Given this list of marker genes EGFR, ROCK1, GRB10, BRCA2, MAPK6, PTK2, ITGAV, ITGA1, CXCL8, CEACAM1, TPR, LIG3, ADAM9, DSP, MDM2, BIRC3, TGFB2, LAMB1, HNRNPH1, TP53BP2, DMD, here is a description of the gene set: studied in species Homo sapiens Cancer related genes down-regulated in any of four hepatoma cell lines following 24 h treatment with TSA. Human Gene Set: CHIBA_RESPONSE_TO_TSA_DN OBJECTIVE: Histone deacetylase (HDAC) inhibitors have been reported to induce cell growth arrest, apoptosis and differentiation in tumor cells. The effect of the HDAC inhibitor, trichostatin A (TSA), on hepatoma cells, however, has not been well studied. In this study, we examined cell viability and gene expression profile in hepatoma cell lines treated with TSA. METHODS: To study cell growth inhibition and induction of apoptosis by TSA on human hepatoma cell lines including HuH7, Hep3B, HepG2, and PLC/PRF/5, cells were treated with TSA at various concentrations and analyzed by the 3-(4, 5-dimethyl-2-thiazolyl)-2H-tetrazolium bromide (MTT) and TUNEL assays, respectively. Changes in gene expression profile after exposure to TSA were assessed using a cDNA microarray consisting of 557 distinct cDNA of cancer-related genes. The levels of acetylated histones were examined by the chromatin immunoprecipitation (ChIP) assay using anti-acetylated histone H3 or H4 antibody. RESULTS: The MTT assay demonstrated that TSA showed cell growth inhibition not only in a concentration-dependent but also a time-dependent manner on all cell lines studied. The TUNEL assay also revealed the potential of TSA to induce apoptosis. The microarray analysis revealed that genes including collagen type 1, alpha2 (COL1A2), insulin-like growth factor binding protein 2 (IGFBP2), integrin, alpha7 (ITGA7), basigin (BSG), quiescin Q6 (QSCN6), superoxide dismutase 3, extracellular (SOD3), nerve growth factor receptor (NGFR), and p53-induced protein (PIG11) exhibited substantial induction (ratio >2.0) after TSA treatment in multiple cell lines. ChIP assay, in general, showed a good correlation between the expression level of mRNA and levels of acetylated histones in these upregulated genes. CONCLUSIONS: This study showed cell growth inhibition and the gene expression profile in hepatoma cell lines exposed to TSA. The alteration in levels of acetylated histones was closely associated with expression of specific cancer-related genes in hepatoma cells. from publication Chiba T, Yokosuka O, Fukai K, Kojima H, Tada M, Arai M, Imazeki F, Saisho H (PMID 15452378)